Given this list of marker genes LY6S, SLURP2, RIC3 (NCBI Gene Id 79608), LY6H, PSCA, DLG4, NRXN1, LYNX1, LY6E, UBXN2A, RAPSN (receptor associated protein of the synapse), LYPD1, APP, RER1, JAK2, here is a description of the gene set: species: Homo sapiens Binding to an acetylcholine receptor. Human Gene Set: GOMF_ACETYLCHOLINE_RECEPTOR_BINDING